Given this list of marker genes NRG2, NRG3, NRG1, HBEGF, ERBB4, ACP4, BTC, EREG, ERBB2, NRG4, here is a description of the gene set: The series of molecular signals initiated by binding of a ligand to the tyrosine kinase receptor ERBB4 on the surface of a cell, and ending with the regulation of a downstream cellular process, e.g. transcription. species: Homo sapiens Human Gene Set: GOBP_ERBB4_SIGNALING_PATHWAY